Given this list of marker genes LAT, MAPK9, CHP1, PTPN6 (NCBI Gene Id 5777), PIK3CA, MAPK3, FOS, DAG1, MAP2K1, PDCD1, MALT1, IKBKG, MAP3K14, CD28, IFNG, CD8A, CD3D, ZAP70, MAP2K7, MAP3K8, ICOS, IL2, PAK1, GRB2, NCK1, PLCG1, JUN, NFATC2, PTPRC, GSK3B, LCK, MAP2K2, SOS1, CBL, CD4, CD40LG, RAF1, GRAP2, PDK1, AKT1, AHSA1, CDK4, IL4 (NCBI Gene Id 3565), NFKB1, DLG1, IKBKB, PRKCQ, RRAS, TNF, LCP2, CSF2, CTLA4, MAP3K7, CALM1, ITK, BCL10, CHUK, IL5 (NCBI Gene Id 3567), IL10, FYN, CARD11, NFKBIA, here is a description of the gene set: Human Gene Set: WP_TCELL_ANTIGEN_RECEPTOR_TCR_PATHWAY_DURING_STAPHYLOCOCCUS_AUREUS_INFECTION species: Homo sapiens T-cell antigen receptor (TCR) pathway during Staphylococcus aureus infection